The following is a description of a gene set: species: Mus musculus part of: Antimicrobial peptides This event has been computationally inferred from an event that has been demonstrated in another species.<p>The inference is based on the homology mapping from PANTHER. Briefly, reactions for which all involved PhysicalEntities (in input, output and catalyst) have a mapped orthologue/paralogue (for complexes at least 75% of components must have a mapping) are inferred to the other species. Reactome Pathway: Ion influx/efflux at host-pathogen interface electronically inferred by orthology from the curated human pathway, and this is the list of marker genes: Pdzd11, Slc11a1